The following is a description of a gene set: species: Mus musculus Mouse Gene Set: GOBP_POSITIVE_REGULATION_OF_FLAGELLATED_SPERM_MOTILITY_INVOLVED_IN_CAPACITATION The process in which the controlled movement of a flagellated sperm cell is initiated as part of the process required for flagellated sperm to reach fertilization competence., and this is the list of marker genes: Defb1, Ccr6, Defb37, Rnase9, Iqcf1